The following is a description of a gene set: from publication Agarwal P, Raghavan A, Nandiwada SL, Curtsinger JM, Bohjanen PR, Mueller DL, Mescher MF (PMID 19592655) Genes down-regulated in comparison of unstimulated CD8 T cells at 48 h versus CD8 T cells at 48 h after stimulation with antigen-B7-1. studied in species Homo sapiens Human Gene Set: GSE15930_STIM_VS_STIM_AND_IFNAB_48H_CD8_T_CELL_DN Differentiation of naive CD8 T cells into cytotoxic effector cells requires three distinct signals- antigen (signal 1), costimulation -B7-1 (signal 2) and cytokine, either interleukin-12 or interferon-a/b (signal 3). Interaction of naive CD8 T cells with antigen and B7-1 programs cell division and proliferation whereas the presence of cytokines- IL-12 or IFNa/b promote survival, differentiation and memory establishment. In the absence of signal 3, the cells interacting with antigen/B7-1 undergo tolerance induction. The objective of this study was to elucidate the mechanisms how the provision of signal 3 promotes differentiation and averts tolerance induction in CD8 T cells. Trichostatin A is a pharmacological agent that inhibits histone deacetylase activity, hence regulating chromatin structure and gene expression and differentiation in many cell types. Gene signature profiles of IL-12, IFNa/b and trichostatin A stimulated cells were compared to elucidate the molecular mechanisms of gene regulation. Oligonucleotide microarray analysis is carried out to determine the extent and molecular nature of the CD8 T cell differentiation program induced by IL-12 or IFNa/b in concert with antigen and B7-1 signal., and this is the list of marker genes: B4GALNT2, AKIRIN1, KPNA6, PLPP3, IFNG, NEURL4, CREG1, IRF5, CXCL10, IFIT2, HAS2, STAM2, DDX24, FAF1, MTHFR, PFDN1, ZNFX1, LDLR, ABCB9, TIMM10, SLCO3A1, SLC2A2, CLIC4 (chloride intracellular channel 4), TRIM21, PPA1, FAH, SPATS2, GPR65, STAT1 (signal transducer and activator of transcription 1), OGFR, SYS1, EIF2AK2, CMPK2, FASLG, ADPRM, ACSL1, FPGS, TAPBP, CTPS1, ZNF131, IGSF10, C1QB, PLAC8, LGALS9B, TRAFD1, SHROOM3, MX2, DNAJC5 (DnaJ heat shock protein family (Hsp40) member C5), MARCHF5, EBI3, GATM, SAMHD1, NT5DC3, COCH, GJA10, IL15, SYNGR2, MAP3K8, SLC7A11, NAMPT, PGS1 (NCBI Gene Id 9489), KRT32 (NCBI Gene Id 3882), NMI, NFKB2 (nuclear factor kappa B subunit 2), MME, PIM1 (Pim-1 proto-oncogene, serine/threonine kinase), TAF1D, ADAR, ATF4, GTF2F2, IFIT1B, SYT1, NOP2 (NCBI Gene Id 4839), VPS72, NOC4L, VPS37B, HLA-DRB1, CEBPB (CCAAT enhancer binding protein beta), COPS7A, IFIT3, UBE2C, TOR1AIP2 (NCBI Gene Id 64163), EIF2AK3, RNF19B, HSPA1A, ST6GALNAC3, BCL2L2, CYP3A7, HUS1, BYSL, E2F1, SEC23B, CASP9, MTHFD2, TCHH, CASP4, COX18, MOV10, BRD2, RSAD2, SRM, RNF11, LRBA (LPS responsive beige-like anchor protein), ZFYVE16, SLFN12L, ALPL, IL10RA, ATP13A1, LYSMD2, IFIH1, GTPBP2 (GTP binding protein 2), UBA7, MID2, FPR3, FURIN, GPAA1, NCF1, CD244, GSTA3, ISG15, SLC22A2, RABGAP1L, SFXN2, PGD, PML, LGALS3BP, PLEKHA5, LSS, GMPPB, MTDH, PHOSPHO2, GFI1, ERCC4, HOMER2, CCRL2 (NCBI Gene Id 9034), PEMT, IRGM, IL15RA, TRAF4, RHOB, ADCY6, TMEM165 (transmembrane protein 165), ST6GALNAC4, IFI27L2, DNAJA3, NAB1, ETNK1, BLTP3A, CCR6, HLA-C, PNP, CALML4, HLA-B (NCBI Gene Id 730410), SERPINB9, PREPL, IFITM3, ISG20, HLA-G, ELOVL2, BAZ1B, IFI35, PSMD1, GEMIN5, TOR1B, TLR7, EDEM3, USP25, E2F5, IRF9 (interferon regulatory factor 9), SKIL, AGRN, IL12RB1, USP18 (NCBI Gene Id 11274), GZMB, COL11A1, IRF7, GPR132, DAXX, TGM2, KAT2B, MPEG1, MX1, ABCA1, SERPINC1, GNG12, ZCRB1, NPY1R, TAP1, ARHGAP5, NAPB, EOMES, CYP7B1, MTMR7 (NCBI Gene Id 9108), SUMO2P7, CLN3, SEC61A2, CMTR1, PI4K2A (phosphatidylinositol 4-kinase type 2 alpha), POMGNT1 (NCBI Gene Id 55624), AUH